Given this list of marker genes ZMPSTE24, MUS81, SMC1A, SLX4, RBM14, FBH1, EME1, APAF1, TIGAR, here is a description of the gene set: species: Homo sapiens Human Gene Set: GOBP_RESPONSE_TO_CELL_CYCLE_CHECKPOINT_SIGNALING A process that occurs in response to signals generated as a result of cell cycle checkpoint signaling.